The following is a description of a gene set: Human Gene Set: GOBP_RESPONSE_TO_IONIZING_RADIATION species: Homo sapiens Any process that results in a change in state or activity of a cell or an organism (in terms of movement, secretion, enzyme production, gene expression, etc.) as a result of a ionizing radiation stimulus. Ionizing radiation is radiation with sufficient energy to remove electrons from atoms and may arise from spontaneous decay of unstable isotopes, resulting in alpha and beta particles and gamma rays. Ionizing radiation also includes X-rays., and this is the list of marker genes: MTA1, KDM4D, XRRA1, NET1 (NCBI Gene Id 10276), BLM, MIR21, TGFB1, FIGNL1, TMEM109, CRYAB, SOD2, LCN2, VCAM1, FANCD2, LZIC, DCUN1D3, INIP, INTS7, BABAM2, XRCC2, CHEK2 (checkpoint kinase 2), BCL2, DCLRE1C, RNF8, PTPRC, H2AX, NUCKS1, PRAP1, GTF2H5, KAT5, MRNIP, TNKS1BP1, EYA3, BARD1, INTS3, ABRAXAS1, UIMC1, PML, CASP3, TP53, GPX1, BRAT1, NHEJ1, CYP2R1, TSPYL5, RAD54L, RAD1, AEN, USP28 (ubiquitin specific peptidase 28), IFI16, HSF1, ABCG5, EEF1D, COP1, SMPD1, XRCC5, RAD9A, BABAM1, ELK1, CDKN1A, ATR, BBC3, CLOCK, BRCA1, IKBIP, MSH2, TP53BP1, EGR1, MAPK14, PRKAA1 (NCBI Gene Id 5562), MAP3K20, BCL2L1, BRCA2, DNMT3A, SWI5, ERCC8, GADD45A, SIRT1, ALAD, LCN10, EYA1, SNAI2, ATM, BAX, INO80, TOPBP1, RPL26, RNF168, RHNO1, LIG4 (NCBI Gene Id 3981), BAK1, KARS1, KDM1A, PARP1, SPIDR, PAXIP1, FBXO4, MDM2, STK11, XRCC6, ECT2, NABP2, CYBA, ITGB6, BRCC3, TREX1, THBD, TNF, CBL, RAD51AP1, TIGAR, CXCL10, XRCC4, PARTICL, NABP1, NIPBL, GRB2, TANK, CLK2, CCND1, CCND2, TOP1, HUS1, ERCC6, RAD54B, RHOB, CCL7, PRKDC, POLB, TLK2, ZMPSTE24, APOBEC1, WRN, ERCC1, GATA3, TICRR, RFWD3, RRM1, SFRP1, RAD9B, MEN1, SFRP2, BRSK1, RAD51, HRAS, YAP1